The following is a description of a gene set: Any process that modulates the frequency, rate or extent of cell killing, the process in which a cell brings about the death of another cell, either in the same or a different organism. studied in species Homo sapiens Human Gene Set: GOBP_REGULATION_OF_CELL_KILLING, and this is the list of marker genes: IL11, CD5L, HLA-A, HLA-H, KLRC4, LILRB1, ARRB2, TGFB2, KLRC3, KLRK1, IL12A, NCR1, CD226, CYRIB, ITGAM, LAMP1, KIR2DL4, CFH, TYROBP, IL13 (interleukin 13), NCKAP1L, KLRD1, HLA-DRB1, KLRC1, NECTIN2, CLEC12B, STAP1, ULBP3, CXCL6, STX7, SH2D1A, IL4, CD59, KLRC4-KLRK1, STAT5A, TGFB1, ULBP1, F2RL1, PRF1, FCGR2B, PVR, HLA-B, ARG1, HAVCR2, INPP5D, KLRB1, IL18RAP, DNASE1, P2RX7, DNASE1L3, MICA, RAET1E (retinoic acid early transcript 1E), FADD, SLC22A13, GRB2, IL12B, CD1E, TAP2, SERPINB4, CR1L, SLAMF6, NCR3, VAV1, PTPRC, LGALS9, CD1C, RAET1G, HLA-C, PPP3CB, CD1B, KLRC2, ULBP2, AZGP1, PIK3R6, IL23R, HLA-DRA, CD55, CR1, ICAM1, CD1A, CD160, IL12RB1, IL7R, LAG3, XCL1, CD1D, TIGIT, AP1G1, NOS2, SERPINB9, HLA-F, RASGRP1 (RAS guanyl releasing protein 1), CX3CR1, MR1, RAET1L, MAPK8, RIPK3, HLA-E, CADM1, AGER, CRTAM, B2M, NECTIN4, IL23A, STAT5B, HLA-G, LEP, CRK, IL21, POMC, IL10, SPI1, CEACAM1